The following is a description of a gene set: The series of molecular signals initiated by interleukin-1 binding to its receptor on the surface of a target cell, and ending with the regulation of a downstream cellular process, e.g. transcription. studied in species Mus musculus Mouse Gene Set: GOBP_INTERLEUKIN_1_MEDIATED_SIGNALING_PATHWAY, and this is the list of marker genes: Il1rn, Ikbkb, Tollip, Rps6ka4, Il1r2 (NCBI Gene Id 16178), Myd88, St18, Irak2, Tirap, Il1rl2, Rps6ka5, Nfkbia, Zbp1, Egr1, Vrk2, Plcb1, Mapk3, Tnip2, Otud4, Il1rap, Il1b, Irak1, Irak4, Il1r1, Irak3, Rela, Il6 (interleukin 6), Traf6, Sigirr